Given this list of marker genes DVL1, APC, SERPINE1, LRRC17, IGFBP3, MMP3, IGFBP2, COL1A2, SPARC, TIMP3, PCDHGC3, TIMP1, CD59, RHOB, ICAM1, RND3, IGF2R, EPHB3 (EPH receptor B3), RHOG, MMP14, RHOA (NCBI Gene Id 387), CD44, TCF7L2 (NCBI Gene Id 6934), ZYX, PAK1, BSG (NCBI Gene Id 682), RHOC, PLAT, LRP1 (NCBI Gene Id 4035), COL3A1, IGFBP5, HSPG2 (NCBI Gene Id 7796), MARCKSL1, PXN, CYTH2, ITGB5, VCAN, FN1, ARHGDIA, COL6A3, ITGA3, MMP19, NID1, NOTCH2, RPSA, RHOQ, LAMA4, JUP, NME2, ITGB2, NME1, COL6A1, CDH6, ADAM9, here is a description of the gene set: Despite major advances in the understanding of the intimate mechanisms of transforming growth factor-beta (TGF-beta) signaling through the Smad pathway, little progress has been made in the identification of direct target genes. In this report, using cDNA microarrays, we have focussed our attention on the characterization of extracellular matrix-related genes rapidly induced by TGF-beta in human dermal fibroblasts and attempted to identify the ones whose up-regulation by TGF-beta is Smad-mediated. For a gene to qualify as a direct Smad target, we postulated that it had to meet the following criteria: (1) rapid (30 min) and significant (at least 2-fold) elevation of steady-state mRNA levels upon TGF-beta stimulation, (2) activation of the promoter by both exogenous TGF-beta and co-transfected Smad3 expression vector, (3) up-regulation of promoter activity by TGF-beta blocked by both dominant-negative Smad3 and inhibitory Smad7 expression vectors, and (4) promoter transactivation by TGF-beta not possible in Smad3(-/-) mouse embryo fibroblasts. Using this stringent approach, we have identified COL1A2, COL3A1, COL6A1, COL6A3, and tissue inhibitor of metalloproteases-1 as definite TGF-beta/Smad3 targets. Extrapolation of this approach to other extracellular matrix-related gene promoters also identified COL1A1 and COL5A2, but not COL6A2, as novel Smad targets. Together, these results represent a significant step toward the identification of novel, early-induced Smad-dependent TGF-beta target genes in fibroblasts. from publication Verrecchia F, Chu ML, Mauviel A (PMID 11279127) Human Gene Set: VERRECCHIA_EARLY_RESPONSE_TO_TGFB1 species: Homo sapiens ECM related genes up-regulated early (within 30 min) in dermal fibroblasts after addition of TGFB1.